The following is a description of a gene set: species: Homo sapiens The multiplication or reproduction of cells, resulting in the expansion of the population in the kidney. Human Gene Set: GOBP_CELL_PROLIFERATION_INVOLVED_IN_KIDNEY_DEVELOPMENT, and this is the list of marker genes: SERPINB7, CFLAR, STAT1, PDGFA, BMP7, MIR125A, IL6R, PDGFB, BMP2 (bone morphogenetic protein 2), ITGB3, MYC, WT1, EGR1, GPC3, LIN28A, GATA3, SHH, BMP4, PDGFRB, PDGFD, OSR1, PTCH1, FLCN